Given this list of marker genes RCVRN, GUCA1C, NCS1, GUCA2B, GUCA1B, GUCA1A, CALM1, GUCA1ANB-GUCA1A, RAF1, GUCA2A, GNAS, CALM2, CALM3, here is a description of the gene set: Human Gene Set: GOMF_CYCLASE_ACTIVATOR_ACTIVITY Binds to and increases the activity of an enzyme that catalyzes a ring closure reaction. species: Homo sapiens